Given this list of marker genes TM6SF1, DNAI1, RBMX, AGPAT5, VSTM2A, MGLL, ARHGEF18, RALA, RPTN, BCL11B (NCBI Gene Id 64919), AGPAT4, PLEKHO1, LMAN2L, ITGB3, POLA2, EIPR1, DNMT3A, ALPK1, DPH5, ADGRL1, ZNF740, PLEKHG2, IL12B, DUSP5, SLC7A14, ADD1, METTL8, CCNJL, DNMT3B, NR4A1, ZSCAN2, RASGRP2, PLCH1, NRIP1, LRRC40, MYLK2, XPO5, ANO6, ICAM5, RTN4RL1, GJD4, FOXRED2, ANKS1A, EIF2B3, SIRT4, ATP1A1, ZMYND12, ARV1, DIP2C, GNGT2, TOPBP1, PEX1, DDR1, ZMYM3, FDFT1, C1QTNF12, CDK6, FBXO9, TNNT2, KIF20B, GK5, GIGYF2, PORCN, PPP1R14A, KTN1, STMN1, MYL11, MAP4K1, BAZ2B, KCNH2, CRYBA1, DCAF17, PRKD3, CCND2, NCOA3, MAP4K4, CAMK2N1, NUDT13, ATXN2, ARSJ, SATB1, NUP58, HELB, EFHC2, CACNA1A, TLK2, SH3BP5L, NMNAT1, TTC3, LPP, MARS1, C14orf28, PIH1D1, EXOC3L1 (NCBI Gene Id 283849), H2AC18, CDC42BPG (NCBI Gene Id 57006), RPRD1A, TECTA, SCEL, NRBP1, GML, EXOC3, INHA, BSPRY (B-box and SPRY domain containing), TSPAN18, SH3PXD2A, BCL2L11, RCBTB2, SLC6A13, LGI2, SYTL2, SLC12A6, TOP1MT, APOBEC4, COMMD2, SYT12, IPO13, TUFT1, WDR41, PEDS1, ENOPH1, MEX3A, NRP2, STMN4, ELP6, PTF1A, RALGPS2, CENPJ, TNFSF4, RBBP8, PI4K2A, SPATA1, FOXO3, TSGA10, RFC1, IRAG1, ZNF219, APBB2, LRATD2 (LRAT domain containing 2), DNAH8, MCUB, GATA3, ZNF175, SSH3, CSNK1E, DLG3, FIBCD1, HERC6, RAD9B, ADCY6, HMBS, NR4A3, CTSW, ITIH3 (inter-alpha-trypsin inhibitor heavy chain 3), ARHGAP20, HSD11B1 (NCBI Gene Id 3290), MAPRE1, KCNMB4, TRPM1, AQP2, RAB3IP, PURG (NCBI Gene Id 29942), CTPS1, GRIK1, RALGPS1, SPINDOC (NCBI Gene Id 144097), ALDH7A1, WDR3, RASA3, ATG4A, ACOT12, TMEM59, MCF2L, VAMP3, SYTL4, ARVCF, NDRG2, DGCR8 (DGCR8 microprocessor complex subunit), COLEC10 (NCBI Gene Id 10584), SMAGP, SLC7A1, COASY, CD300LG, BASP1, MOV10L1, MS4A1, TDRD5, RBMS2, MRPL13, KDM1A (lysine demethylase 1A), MYO7B, RREB1, STYXL1, FCGR2A, RPP30, OASL, FBXO30, REEP4, GALC, here is a description of the gene set: Human Gene Set: GSE40441_NRP1_POS_INDUCED_TREG_VS_NRP1_NEG_NATURAL_TREG_DN species: Homo sapiens Genes down-regulated in T reg: NRP1+ versus NRP1-. To compare subpopulations of Treg cells in wild type mice based upon Nrp1 Expression, differentiating nTreg and iTreg from publication Weiss JM, Bilate AM, Gobert M, Ding Y, Curotto de Lafaille MA, Parkhurst CN, Xiong H, Dolpady J, Frey AB, Ruocco MG, Yang Y, Floess S, Huehn J, Oh S, Li MO, Niec RE, Rudensky AY, Dustin ML, Littman DR, Lafaille JJ (PMID 22966001)